The following is a description of a gene set: part of: Class A/1 (Rhodopsin-like receptors) Reactome Pathway: Amine ligand-binding receptors This event has been computationally inferred from an event that has been demonstrated in another species.<p>The inference is based on the homology mapping from PANTHER. Briefly, reactions for which all involved PhysicalEntities (in input, output and catalyst) have a mapped orthologue/paralogue (for complexes at least 75% of components must have a mapping) are inferred to the other species. electronically inferred by orthology from the curated human pathway studied in species Mus musculus, and this is the list of marker genes: Chrm1, Hrh2, Adrb3 (NCBI Gene Id 11556), Htr1a, Htr1f, Htr1b, Taar8b, Drd4, Adra2c, Chrm2 (NCBI Gene Id 243764), Drd5, Hrh4 (histamine receptor H4), Htr5a, Taar9, Chrm3, Adra2b, Drd2, Taar1, Htr2c, Drd3, Adrb1, Hrh1, Adra2a, Taar5 (trace amine-associated receptor 5), Taar8c, Htr4, Htr6, Hrh3, Taar3 (NCBI Gene Id 493809), Gpr143, Htr7, Adra1a (NCBI Gene Id 11549), Chrm4